Given this list of marker genes ACTC1, FXYD1, FGF2, SSPN, BDKRB2, COL6A3, ACTG2, CASQ2, KCNH2, SPEG, TNNI2, NEB, FHL1, CALD1, PLN, MYOD1, LAMA2, ACTA2, MYOM1, EDNRA, MYH11, ADAM12, MYF6, SGCG, IGF1, HRC, CHRNB1, VIPR1, CSRP3, SCN5A, MYOM2, TNNT3, FLII, MYH7, FKBP1B, PPP1R12B, MYL7, MYL1, CKMT2, GJA1, MYBPC1, AEBP1, MYH3, NOS1, GJA5, ACTA1, CRYAB, RYR1, ALDOA, here is a description of the gene set: species: Homo sapiens Genes in the cancer module 387. Human Gene Set: MODULE_387